Given this list of marker genes Jak2, Irs2, Pik3cd, Pik3ca, Lyn, Pik3r1, Pik3r5, Epor, Pik3cb, Pik3cg, Gab1, Epo, here is a description of the gene set: Mouse Gene Set: REACTOME_ERYTHROPOIETIN_ACTIVATES_PHOSPHOINOSITIDE_3_KINASE_PI3K Erythropoietin activates Phosphoinositide-3-kinase (PI3K) studied in species Mus musculus